Given this list of marker genes Polr2h, Tbp, Cdc73 (cell division cycle 73, Paf1/RNA polymerase II complex component), Polr2l, Polr2d, Polr2b, Polr2e, Polr2g, Gtf2a1, Gtf2h4, Ccnh, Gtf2b, Gtf2e2, Tuft1, Mnat1, Usp22, Kat2a, Taf10, Psmc5, Taf5l, Ctr9, Polr2c, Rtf1, Trrap, Taf6l, Gtf2a2, Gtf2a1l, Leo1, Gtf2f2, Paf1, Taf12, Gtf2h5, Taf9b, Polr2i, Taf6, Tcea1, Polr2m, Taf7l, Gtf2h2, Cdk7, Atxn7, Eny2, Ercc2, Polr2j, Taf5, Supt3, Polr2f, Ercc3, Taf4b, Polr2k, Atxn7l3, Taf11, Polr2a, Tbpl1, Taf2, Taf8, Gtf2h3, Taf4, Taf13, Pex2, Taf1 (NCBI Gene Id 270627), Gtf2e1, Myzap, Taf3, Gtf2f1, Skic8, Taf7, Taf9, Tada3, Gtf2h1, here is a description of the gene set: Mouse Gene Set: GOCC_RNA_POLYMERASE_II_HOLOENZYME studied in species Mus musculus A nuclear DNA-directed RNA polymerase complex containing an RNA polymerase II core enzyme as well as additional proteins and transcription factor complexes, that are capable of promoter recognition and transcription initiation from an RNA polymerase II promoter in vivo. These additional components may include general transcription factor complexes TFIIA, TFIID, TFIIE, TFIIF, or TFIIH, as well as Mediator, SWI/SNF, GCN5, or SRBs and confer the ability to recognize promoters.